Given this list of marker genes Dram1, Acot1 (acyl-CoA thioesterase 1), Cd36, Hspa2, Vldlr, Elapor1, Usp18, Slc25a4, Elovl7, Cyp39a1, Abcd2, Ctse, Psat1, Gsn, Slc44a3, Ren1, Serpina7, Hao2, Cyp2b9, Cpt1b, Il1rn, Pcp4l1 (NCBI Gene Id 66425), Lepr, Ifi44, Fmo3, Amy2a5, Defb1, Acot3 (NCBI Gene Id 171281), Rad51b, Car3, Slc27a1, Slc22a26, Emp2, Qpct, Rcan2, Rab27a, Sult1e1, Gadd45b, Ddr1, Lysmd2, Slc2a4, Anxa13, Prom1, Sult2a1, Nrg4, Smpx, Gstm3, Slc16a7, Txnip, Pdk4, Abcb1a, here is a description of the gene set: Mouse Gene Set: OHGUCHI_LIVER_HNF4A_TARGETS_UP Type 1 iodothyronine deiodinase (Dio1), a selenoenzyme catalyzing the bioactivation of thyroid hormone, is highly expressed in the liver. Dio1 mRNA and enzyme activity levels are markedly reduced in the livers of hepatocyte nuclear factor 4alpha (HNF4alpha)-null mice, thus accounting for its liver-specific expression. Consistent with this deficiency, serum T4 and rT3 concentrations are elevated in these mice compared with those in HNF4alpha-floxed control littermates; however, serum T3 levels are unchanged. Promoter analysis of the mouse Dio1 gene demonstrated that HNF4alpha plays a key role in the transactivation of the mouse Dio1 gene. Deletion and substitution mutation analyses demonstrated that a proximal HNF4alpha site (direct repeat 1; HNF4alpha-RE) is crucial for transactivation of the mouse Dio1 gene by HNF4alpha. Mouse Dio1 is also stimulated by thyroid hormone signaling, but a direct role for thyroid hormone receptor action has not been reported. We also showed that thyroid hormone-inducible Krüppel-like factor 9 (KLF9) stimulates the mouse Dio1 promoter very efficiently through two CACCC sequences that are located on either side of HNF4alpha-RE. Furthermore, KLF9 functions together with HNF4alpha and GATA4 to synergistically activate the mouse Dio1 promoter, suggesting that Dio1 is regulated by thyroid hormone in the mouse through an indirect mechanism requiring prior KLF9 induction. In addition, we showed that physical interactions between the C-terminal zinc finger domain (Cf) of GATA4 and activation function 2 of HNF4alpha and between the basic domain adjacent to Cf of GATA4 and a C-terminal domain of KLF9 are both required for this synergistic response. Taken together, these results suggest that HNF4alpha regulates thyroid hormone homeostasis through transcriptional regulation of the mouse Dio1 gene with GATA4 and KLF9. studied in species Mus musculus Genes up-regulated in liver samples of liver-specific knockout of HNF4A. from publication Ohguchi H, Tanaka T, Uchida A, Magoori K, Kudo H, Kim I, Daigo K, Sakakibara I, Okamura M, Harigae H, Sasaki T, Osborne TF, Gonzalez FJ, Hamakubo T, Kodama T, Sakai J (PMID 18426912)